The following is a description of a gene set: studied in species Homo sapiens Human Gene Set: GOCC_GID_COMPLEX A protein complex with ubiquitin ligase activity that, in Saccharomyces cerevisiae, is involved in proteasomal degradation of fructose-1,6-bisphosphatase (FBPase) and phosphoenolpyruvate carboxykinase during the transition from gluconeogenic to glycolytic growth conditions. It appears to play a broader role in cellular homeostasis and development in other species., and this is the list of marker genes: ARMC8, RMND5A (required for meiotic nuclear division 5 homolog A), WDR26, RMND5B (required for meiotic nuclear division 5 homolog B), MAEA